The following is a description of a gene set: species: Homo sapiens Neighborhood of DEK Neighborhood of DEK DEK oncogene (DNA binding) in the MORF expression compendium Human Gene Set: MORF_DEK, and this is the list of marker genes: MSH6, ATXN10, SRSF1, RAD23A, SEC61B, SUMO2, LSM7, YWHAZ, HSP90AA1, HSPA8, RAD21, SRP9, AFG3L2, SRRM1, KIF2A, COX7B, CTDNEP1, DUT, SDHA, GPN1, DGUOK, HNRNPA2B1, DDX49, ANAPC5, RPL21, METAP1, KHDRBS1, OXA1L, TRAPPC3, CANX, RFC4, H2AZ2, BZW1, ILF3, PCBP2, VDAC2, AP3S1, TERF2IP, EBP, IFRD1, LDHA (NCBI Gene Id 3939), LSM2, RTCB, POM121, CSNK2B, HNRNPU, RHEB, FBL, NAP1L1, R3HDM1 (NCBI Gene Id 23518), MSH2, PRPF31, CAPZA1, HNRNPM (NCBI Gene Id 4670), YWHAB, SREBF2, SRSF9, CUL1, CNBP, IDH3B, AATF, XPO1, HNRNPR, PCLAF, CHERP, PRPS1, UBE2E1, DNAJC8, EIF4H, FUS, HDAC2, PGK1, PSMB7, SRP14, ACAA2, U2AF1, PARK7, EIF1AX, ITGB3BP, DEK, CYC1, SSBP1, H2AZ1, DRG1, STARD7, MARCHF7, GNB1, DHX38, SON, CBX3, TRA2B, HNRNPA3P1, HADHB, PSMB4, PPP2CA, SLC25A3, HUWE1, KDM3B, CTCF, PUF60, UBE2I, COPS5, IST1, CDK2, MRPL9, MTDH, UQCRFS1, CTBP1, TRIM28, ICE1, CLTC, RPS27A, CALM2, FAM120A, COX7A2L, PSMA2, SLC25A5, ARPC5, HMGB2, NONO, NUDT1, ANP32B, GPAA1, STOML2, RPL36AL, BCL7B, ETF1, DOCK3, SNRNP200, PPM1G, COX7C, NCL, PRPF8, RNPS1, PRRC2C, COPS6, ATP5MC3, NAP1L4, PSMA4, SMC1A, SEPTIN7, TARDBP, EIF3K, ILF2, CRKL, NIPSNAP2, CDC123, KARS1, PUM1, COA1, STK24, AURKB, GDI2, HNRNPA0, PHB2, PRMT1, HTATSF1, HAT1, NDUFV1, IK, FAM168B, RAN, RAF1, UQCRB, SERP1, ACLY, SUMO1, TAF11, FBXW11, RTN4, SP3, SOD1, POLR2A, ERH, C1QBP, HNRNPK, EIF3I (eukaryotic translation initiation factor 3 subunit I), TMEM123, XRCC5, LYPLA1, SAFB, UBE2L3, HNRNPD, MDH1, SEC61G, CCT7, XRCC6, COX4I1, ATP5PF, G3BP2, TUFM, BRD8, IFT25, HNRNPUL1, SYNCRIP, JTB, CS, RPL6, CCT2, POLE3, KXD1, NSA2, SNRPA, SEM1, HDAC1, SET (NCBI Gene Id 6418), PUM2, EIF4A2, TCEA1, ATP5PO, KRIT1 (NCBI Gene Id 9602), NACA, SNRPE, RALY (RALY heterogeneous nuclear ribonucleoprotein), SEC63, SDR39U1, SRSF3, TOP1, DDX39B, PCMT1, ARFGAP2, UBA2, ACYP1, TIAL1, EIF3M, XPO6, EIF3H, ACP1, PSMB2, NUP188, HMGN1, SNRPB, HNRNPAB, HPRT1, LRPPRC, SUMO3, RBMX (RNA binding motif protein X-linked), BUB3, GANAB, USP1, RANBP1, SSB, ZZZ3, PSMB1, SKP1, XPO7, UQCRH, PCNA, SMNDC1, SYPL1, YWHAQ, CLNS1A, DAP3, FOXJ3, NDUFS3, BANF1, POLR2I, EIF4A1, MCM2, RPA1, HNRNPC, ZC3H15, PIN1, DDX39A